The following is a description of a gene set: Mouse Gene Set: chr1G3 species: Mus musculus, and this is the list of marker genes: Angptl1, Rnasel, Rgs16, Fam163a (family with sequence similarity 163, member A), Tex35, Gm5532, Gm8818, E330020D12Rik, Apobec4, Glul, Arpc5, A430050A11Rik, Ncf2, Gm36934, Gm18727, Soat1, Shcbp1l, 5530400K19Rik, Npl, Mr1, Qsox1, Gm23744, Dhx9, Csnk2a1-ps3, Abl2, Xpr1 (NCBI Gene Id 19775), Tor1aip1, Gm10531, Gm19918, Teddm1b, 9430034N14Rik, Lhx4, Gm15428, Ier5, Gm25588, Gm8976, 4930532M18Rik, Tor1aip2, Tor3a, Gm37383, Stx6, BC034090, Gm9530, Rpl35rt, Gm30694 (NCBI Gene Id 102632688), Gm37943, Gm9694, Lamc1, Teddm2, Zfp648, Rgs8, Gm8850, 1700040K01Rik, Axdnd1, 4930518J20Rik, Tdrd5, Rgsl1, Cacna1e, 4930452N14Rik, Nmnat2 (nicotinamide nucleotide adenylyltransferase 2), Gm28513, Fam20b, Nphs2, Mir8114, A830008E24Rik (NCBI Gene Id 414092), Gm6652, Teddm1a, Ralgps2, Gm25336, Smg7, Cep350, Rgl1, Acbd6, Lamc2, 4930439D14Rik